The following is a description of a gene set: Human Gene Set: GOBP_FAT_PAD_DEVELOPMENT studied in species Homo sapiens The progression of a fat pad from its initial formation to its mature structure. A fat pad is an accumulation of adipose tissue., and this is the list of marker genes: HMGA2, ARID5B, ARRDC3, FOSL2, BBS4, DGAT2, TBL1XR1, CASR, ERRFI1, UBB